The following is a description of a gene set: Human Gene Set: HP_AMYOTROPHIC_LATERAL_SCLEROSIS studied in species Homo sapiens Amyotrophic lateral sclerosis, and this is the list of marker genes: PPARGC1A, ALS2, MAPT, PON3, PRPH, HNRNPA2B1, FIG4, ERBB4, UNC13A, ANXA11, CCNF, NEFH, TREM2, TAF15, UBQLN2, SETX, C9orf72, CHMP2B, TIA1, MATR3, NEK1, GLT8D1, CFAP410 (cilia and flagella associated protein 410), SPG11, PON2, SIGMAR1, HNRNPA1, VAPB, GLE1, TRPM7, PSEN1, DAO, TUBA4A, CHCHD10, ANG (angiogenin), FUS (FUS RNA binding protein), PFN1, TBK1, VCP, SOD1, CYLD, SQSTM1, DCTN1, ATXN2, TARDBP, PON1, SPTLC1, KIF5A, OPTN